Given this list of marker genes MYO18A, MYH7, LIMCH1, MYH6, MYH1, MYH4, MYL11, MYL1, MYH14, MYH3, MYH13, MYL5 (NCBI Gene Id 4636), MYL12A, MYO18B, MYH9 (myosin heavy chain 9), MYL12B, MYL6, MYH2, MYL9, MYH11, MYL3, MYL6B, MYH7B, MYL4, MYH8, MYH10 (NCBI Gene Id 4628), MYH15, here is a description of the gene set: A myosin complex containing two class II myosin heavy chains, two myosin essential light chains and two myosin regulatory light chains. Also known as classical myosin or conventional myosin, the myosin II class includes the major muscle myosin of vertebrate and invertebrate muscle, and is characterized by alpha-helical coiled coil tails that self assemble to form a variety of filament structures. species: Homo sapiens Human Gene Set: GOCC_MYOSIN_II_COMPLEX